The following is a description of a gene set: Any developmental process that results in the creation of defined areas or spaces within the kidney to which cells respond and eventually are instructed to differentiate. studied in species Mus musculus Mouse Gene Set: GOBP_PATTERN_SPECIFICATION_INVOLVED_IN_KIDNEY_DEVELOPMENT, and this is the list of marker genes: Foxd1, Irx1, Irx3, Osr1, Pax8, Hes5, Irx2, Pax2